Given this list of marker genes PON3, SOCS1, FGL2, SRRM4, CCL1, LMO4, TCF21, RGL1, CCL5, TBK1, ANXA7, MAPKAPK5 (NCBI Gene Id 8550), TAB2, ZNF276, HNRNPD, ZDHHC20, CST7, APBB2, CYS1, ATP10A, PARP14, HMOX1, FST (follistatin), PSMB7, RCSD1, REPS1, HELZ2, PSMA2, IZUMO1R (IZUMO1 receptor, JUNO), RBM7, TLNRD1, RIPK2, VPS37C, MMP2, MACROH2A1, NTMT1, BLCAP, PKP4, EIF2S2, TSPAN33, PIK3CG (phosphatidylinositol-4,5-bisphosphate 3-kinase catalytic subunit gamma), EVC, CES3, DNAJB1 (DnaJ heat shock protein family (Hsp40) member B1), THOC1, CDH6, BDKRB2, WASHC3, TIMELESS, TMEM100, SCLY, DOCK6, SLC6A8, IL11, SLC1A3, ZDHHC6 (NCBI Gene Id 64429), IBSP, SYPL1, CGGBP1, PSD, RAB3IP, IL18, RAB32, MTMR7, DNER, POLE4, GDE1, NOP58, ACTN1, TTC1 (NCBI Gene Id 7265), ELOC, TSC22D1, CLCF1, GYPC, FKBP1A, PSMA4, LZTFL1, CPD, MAT1A, SLC31A1, EBI3, GSDME, TEK, DDX4, MCMBP, IGFBP2, SNX16, SENP1, NDRG2, NECTIN2, RAI14, PTPN6, SLC13A1, TESK1, NUB1, PSME3, IFT172, ASB15, JMJD6, GFPT1, ASB12, CNOT2, CD72, PNO1, PPP1R2P1, PDLIM4, MX1, LRRC46, C6orf62, CNOT9, PCDH8, LYN, MTDH, IFITM10, ECE2, FBLN5, CTTN, PALLD, PLAGL2 (NCBI Gene Id 5326), MANEAL, STARD3 (StAR related lipid transfer domain containing 3), HOXA9, IFNA1, NR0B2, RAB10, NCMAP, DDIT3, PRSS42P, PSMD6, PPP1R14D, FLNB, UBE4A, FADD, CTCF (CCCTC-binding factor), PPP1R15A, PTCD1, SLC6A13, PEF1, LBX1, CCDC71L, SLC16A4, UBOX5, MYD88, GTF2B, PTPN11, HRH3, C21orf91, SLTM, NIP7, TNFSF9, CD70, KTN1, BLOC1S6, OLR1, KCMF1, GNB1, SLAMF8, ITGB1, SERPINB9, EEF1E1, SEPTIN8, VCAN, SPTSSB, IGF2BP1, TTR, STXBP1, UBE2I, CPZ, PMPCB, E2F8, WASHC4, HDAC1, INTS8, SQSTM1, YARS1, GSDMC, SOD2, ZFAND3, GRINA, HOXB2, METAP1, DDX51, PIM1, APOBEC2, PPIG, EIF2S1, CLIP1, SPAST (spastin), HINFP, ATF3 (activating transcription factor 3), COL4A4, GLRX, CCR4, GCH1, APPBP2, SLC30A3, CCNL1, FGF11 (NCBI Gene Id 2256), PRKD1, here is a description of the gene set: Human Gene Set: GSE17721_CTRL_VS_CPG_12H_BMDC_DN species: Homo sapiens mouse primary BMDCs were stimulated with tlr ligands and gene expression changes were profiled on Affymetrix arrays from publication Amit I, Garber M, Chevrier N, Leite AP, Donner Y, Eisenhaure T, Guttman M, Grenier JK, Li W, Zuk O, Schubert LA, Birditt B, Shay T, Goren A, Zhang X, Smith Z, Deering R, McDonald RC, Cabili M, Bernstein BE, Rinn JL, Meissner A, Root DE, Hacohen N, Regev A (PMID 19729616) Genes down-regulated in comparison of control dendritic cells (DC) at 12 h versus those stimulated with CpG DNA (TLR9 agonist) at 12 h.